The following is a description of a gene set: species: Homo sapiens Positive epigenetic regulation of rRNA expression Human Gene Set: REACTOME_POSITIVE_EPIGENETIC_REGULATION_OF_RRNA_EXPRESSION, and this is the list of marker genes: MTA1, POLR2L, POLR1D, H4C15, POLR1E, POLR1H, DEK, TAF1C, RBBP7, GATAD2A, H2AC7, H2BC4, H4C6, H2AC14, H4C3, SMARCA5, H4C12, POLR2K, CBX3, H2AX (H2A.X variant histone), H4C1, H4C4, POLR1C, H4C11, MTA2, H3C1, H2BC1, H2BC15, H2BC5 (H2B clustered histone 5), H3C4, H2BC10, EP300, MBD3, H2BC26, H4C16, H3C6, CHD3, HDAC2, MYO1C, ERCC6, H4C14, RBBP4, BAZ1B, POLR1B (NCBI Gene Id 88998), H4C8, H3C8, POLR2H, H2BC13, POLR1G, H4C13, H2BC9, TTF1, EHMT2, TAF1A, TAF1B, MYBBP1A, H2AC20, H2BC21, H3C15, H2BC17, POLR1F, H4C9 (H4 clustered histone 9), POLR2E, H3C7, GATAD2B, MTA3, H2BC8, KAT2A, HDAC1, H2AJ, SF3B1, H2AB1, H2AC6, H3-3A, H3C10, CHD4, DDX21, POLR1A, H2BC14, H2AC4 (NCBI Gene Id 8335), H2BC11, H2BC12L, H3C11 (H3 clustered histone 11), H3-3B, TAF1D, H4C5, H3C13, H2BC12, H2BC6, H3C3, KAT2B, H2BC3, H2AC8, H2AC18 (NCBI Gene Id 8337), GSK3B (glycogen synthase kinase 3 beta), H3C14, POLR2F, H3C2, H4C2, H2AZ2, H2AC19, H2BC7, H3C12, ACTB (actin beta), TBP